Given this list of marker genes Slc18a1, Slc22a3, Nos1, Slc18b1, Snca, Slc18a2, Slc22a2, Slc29a4, Slc6a4, Fev, Gpm6b, Slc18a3, Itgb3, Slc22a1, here is a description of the gene set: The directed movement of serotonin into a cell, typically presynaptic neurons or glial cells. Serotonin (5-hydroxytryptamine) is a monoamine neurotransmitter occurring in the peripheral and central nervous systems. Mouse Gene Set: GOBP_SEROTONIN_UPTAKE studied in species Mus musculus